Given this list of marker genes CDK5, MT-TE, MTRFR, NDUFAF5, CYC1, MRPS25, NARS2 (asparaginyl-tRNA synthetase 2, mitochondrial), MRPS16, SCO2, RRM1, TOP3A, DNAJC30, NDUFV2, PUS1, MTFMT, VCP, SLC25A10, PEX5, GTPBP3, NDUFS6, TRMT10C, AIFM1, COA5, UQCRH, PREPL, MT-TL1, MT-ND1, NDUFB11, NFU1, SUCLA2, GFER, NDUFA12 (NCBI Gene Id 55967), ATP5F1E, NDUFS3 (NADH:ubiquinone oxidoreductase core subunit S3), SLC3A1, TARDBP (NCBI Gene Id 81927), MGME1 (mitochondrial genome maintenance exonuclease 1), OPA1 (NCBI Gene Id 4976), NDUFA10, ISCU, DGUOK (NCBI Gene Id 1716), SFXN4, TSFM, NFS1, NDUFB9, NDUFB8, SDHD, ISCA2, MMP1, ETFB, COX4I1, CHKB, ETFA, BCS1L, COX5A, DNA2, SCO1, SDHB, MYH7, ACAD8, PPM1B, PNPT1, NDUFS4, ACADVL, COA8 (NCBI Gene Id 84334), NDUFAF8, CRLS1, TXN2, TRMU, ATP5F1A, TFAM, COA3, AARS2, DNMT1 (DNA methyltransferase 1), ACAD9, NDUFV1, VARS2, IBA57, UQCRB, TRIT1, HSD17B10, SLC39A8, SDHA, MIEF2, MT-CO1, NDUFAF2, MT-TF, QRSL1, MT-TQ, SCN4A, RARS2, C1QBP, NDUFA9, TTN, MT-ND6, DNM1L, MRPS23, GNE, COQ4 (coenzyme Q4), NDUFA6 (NCBI Gene Id 4700), GGPS1, TK2, GFM2, LIG3, NDUFA4, LIAS, NDUFA11, CHCHD10, POLG2, NDUFB3, NDUFC2, AK2, MRPL39, NDUFA2, DLD, TYMP, NDUFA13, MT-ND4, MT-CO3 (NCBI Gene Id 4514), MT-ND4L, COX6A2, SPG7, HADH, ECHS1, COX20, LYRM7, PDHA1, TMEM70, ATP5F1D (NCBI Gene Id 513), CTNS, SLC25A20, LRPPRC, MTO1, NAXE, CPT2, EHHADH, MECR, TRMT5, SLC25A3, ACADM, MRM2, CYBA, SLC34A1, HACD1, GFM1, KARS1, MT-ND2, PIGA, ELAC2, SQSTM1, TIMMDC1, BOLA3, FBXL4, UQCC3, NDUFB7 (NADH:ubiquinone oxidoreductase subunit B7), NDUFA8, TIMM22, NDUFS8, MYH14, AFG3L2, TWNK, GATC, MFF, MT-ND5, EARS2, PDHX, COX16, FUS, AHDC1, GATM, MT-TL2, HIBCH, CAMKMT, NDUFA1, FH, PTCD3, ATPAF2, TIMM50, NDUFAF3, NDUFS1, MT-TW, FDXR, SLC22A5, MT-TS2, NEB, NDUFAF6, UQCRQ, MT-TH, RRM2B, HADHA, COL7A1, PET117, MPV17, NDUFS7, NSUN3, LYRM4, PDHB, FLAD1, ETFDH, COA6, CYBB, CARS2, NUBPL, GYG1, TTC19, TBK1, MT-ND3, MCCC2, POLG, DLAT, TAFAZZIN, TAMM41, NDUFS2, MT-CYB, CYP27A1, FDX2, MT-TN, UQCC2, SLC25A4, TMEM126B, YARS2, MRPS22, MT-CO2, NDUFAF1 (NADH:ubiquinone oxidoreductase complex assembly factor 1), NADK2, NDUFAF4, FOXRED1, FXN, AGK, MRPL12, GLRX5, MT-ATP6, NDUFB10, HMGCL (NCBI Gene Id 3155), MRPS14, SUCLG1, SLC25A26, PET100, PDP1 (NCBI Gene Id 5497), TEFM, here is a description of the gene set: species: Homo sapiens An anomaly of the mitochondrion, the membranous cytoplasmic organelle the interior of which is subdivided by cristae. The mitochondrion is a self replicating organelle that is the site of tissue respiration. Abnormality of the mitochondrion Human Gene Set: HP_ABNORMALITY_OF_THE_MITOCHONDRION